Given this list of marker genes Smpd1, Glb1l2, St3gal2, Fut2, B4galt6, Hexb, Arsj, Psap, St3gal5, Sts, St6galnac6, B3galnt1, St8sia5, Gba2, Neu1, Gba1, Glb1l3, Arsa, Arsi (NCBI Gene Id 545260), St3gal3, Smpd4, Neu3, Hexa, Sumf2, Arsg, Fut1, Asah2, Cerk, Glb1l, M6pr, Neu4, Sumf1, Smpd2, Neu2, B3galt4, here is a description of the gene set: electronically inferred by orthology from the curated human pathway part of: Sphingolipid metabolism Reactome Pathway: Glycosphingolipid metabolism species: Mus musculus This event has been computationally inferred from an event that has been demonstrated in another species.<p>The inference is based on the homology mapping from PANTHER. Briefly, reactions for which all involved PhysicalEntities (in input, output and catalyst) have a mapped orthologue/paralogue (for complexes at least 75% of components must have a mapping) are inferred to the other species.